The following is a description of a gene set: Recently, enzymes of the tricarboxylic acid (TCA) cycle have emerged as novel tumor suppressors. In particular, mutations in the nuclear-encoded subunits of succinate dehydrogenase (SDHB, SDHC, and SDHD) cause paragangliomas and pheochromocytomas. Although the mechanism(s) by which disruption of mitochondrial metabolism leads to neoplasia is largely unknown, increasing evidence points to an activation of pseudohypoxia. In this study, we have shown that silencing of SDHB using DNA-based small interfering RNA resulted in major impairments in cellular proliferation, respiration, and a corresponding shift to glycolysis. The levels of reactive oxygen species, however, were unchanged. As expected, hypoxia-inducible factor-1 alpha (HIF-1 alpha) and HIF-2alpha were up-regulated in chronically silenced cells, suggesting that a pseudohypoxic state was attained. In addition, the c-Jun amino-terminal kinase and p38 kinase stress signaling proteins were hyperphosphorylated in SDHB-silenced cells. Microarray analysis showed that >genes were influenced (6-fold or more up-regulation or down-regulation) by silencing of SDHB, confirming the importance of the TCA cycle in cellular metabolism. Examples of dysregulated genes included those involved in proliferation, adhesion, and the hypoxia pathway. Of interest, SDHB-silenced cells had a greater capacity to adhere to extracellular matrix components, including fibronectin and laminin, than control cells, thus suggesting a possible mechanism of tumor initiation. Although transient silencing of the HIF-1 alpha transcription factor in SDHB-silenced cells had little effect on the expression of a subset of up-regulated genes, it partially reversed the adhesion phenotype to fibronectin, pointing to a potentially important role for HIF-1 in this process. Human Gene Set: CERVERA_SDHB_TARGETS_1_DN species: Homo sapiens from publication Cervera AM, Apostolova N, Crespo FL, Mata M, McCreath KJ (PMID 18519664) Genes turned off in Hep3B cells (hepatocellular carcinoma, HCC) upon knockdown of SDHB by RNAi., and this is the list of marker genes: NPTX2, ZBTB16, PEG10, CCR6, AFP, PPFIBP2, ITPR2, ADH6, PLA2G7, FTCD, A1BG, F2, HSPA1A, HMGCS2, LYZ, SULT2A1, EYA4, SCGN, CADPS, TTYH1, CHODL, PEG3, SOX2, ZNF703, ANGPTL3, NINJ2-AS1, MEP1A, PDE3A, PWWP3B, CPS1, TMC8, SLC39A5, FJX1, MMP16, SH3RF3, ALDOC